Given this list of marker genes SFRP1, LBX2, MLLT3, PLEKHA4, ABL1, NKD1, DKK1, WNT5A, CSNK1E, DAB2, CSNK1D, WNT5B, ANKRD6, RSPO3, GPC3, here is a description of the gene set: studied in species Homo sapiens Human Gene Set: GOBP_POSITIVE_REGULATION_OF_NON_CANONICAL_WNT_SIGNALING_PATHWAY Any process that activates or increases the frequency, rate or extent of non-canonical Wnt-activated signaling pathway.